Given this list of marker genes GAPDHS, TPI1, PCK1, FBP2, ALDOA, G6PC3, ENO4, G6PC2, PC, GAPDH, SLC37A1, G6PC1, ENO1, SLC37A2, SLC37A4, ENO2, PCK2, ALDOC, PGAM1, ALDOB, GPI, PGK1, FBP1, ENO3, PGK2, PGAM2, here is a description of the gene set: part of: Glucose metabolism species: Homo sapiens Reactome Pathway: Gluconeogenesis Gluconeogenesis converts mitochondrial pyruvate to cytosolic glucose 6 phosphate which in turn can be hydrolyzed to glucose and exported from the cell. Gluconeogenesis is confined to cells of the liver and kidney and enables glucose synthesis from molecules such as lactate and alanine and other amino acids when exogenous glucose is not available (reviewed, e.g., by Chourpiliadis & Mohiuddin 2022). Gluconeogenesis occurs in two parts: a network of reactions converts mitochondrial pyruvate to cytosolic phosphoenolpyruvate; then phosphoenolpyruvate is converted to glucose 6 phosphate in a single sequence of cytosolic reactions.<p>Three variants of the first part of the process are physiologically important. 1) A series of transport and transamination reactions convert mitochondrial oxaloacetate to cytosolic oxaloacetate which is converted to phosphoenolpyruvate by a hormonally regulated, cytosolic isoform of phosphoenolpyruvate carboxykinase. This variant allows regulated glucose synthesis from lactate. 2) Mitochondrial oxaloacetate is reduced to malate, which is exported to the cytosol and re oxidized to oxaloacetate. This variant provides reducing equivalents to the cytosol, needed for glucose synthesis from amino acids such as alanine and glutamine. 3) Constitutively expressed mitochondrial phosphoenolpyruvate carboxykinase catalyzes the conversion of mitochondrial oxaloacetate to phosphoenolpyruvate which may then be transported to the cytosol. The exact path followed by any one molecule of pyruvate through this reaction network is determined by the tissue in which the reactions are occurring, the source of the pyruvate, and the physiological stress that triggered gluconeogenesis.<p>In the second part of gluconeogenesis, cytosolic phosphoenolpyruvate, however derived, is converted to fructose 1,6 bisphosphate by reactions that are the reverse of steps of glycolysis. Hydrolysis of fructose 1,6 bisphosphate to fructose 6 phosphate is catalyzed by fructose 1,6 bisphosphatase, and fructose 6 phosphate is reversibly isomerized to glucose 6 phosphate.<p>In all cases, the synthesis of glucose from two molecules of pyruvate requires the generation and consumption of two reducing equivalents as cytosolic NADH + H+. For pyruvate derived from lactate (variants 1 and 3), NADH + H+ is generated with the oxidation of lactate to pyruvate in the cytosol (a reaction of pyruvate metabolism not shown in the diagram). For pyruvate derived from amino acids (variant 2), mitochondrial NADH + H+ generated by glutamate dehydrogenase (a reaction of amino acid metabolism, not shown) is used to reduce oxaloacetate to malate, which is transported to the cytosol and re oxidized, generating cytosolic NADH + H+. The synthesis of glucose from pyruvate also requires the consumption of six high energy phosphates, four from ATP and two from GTP.